Given this list of marker genes Arx, Lhx6, Pafah1b1, Cntn2, Drd1, Sox1 (SRY (sex determining region Y)-box 1), Nkx2-1, Fat3, Rac1, Nr2f1, Fezf1, Reln, Drd2, Ccr4, Evx1, Nr2f2, Fezf2, here is a description of the gene set: Mouse Gene Set: GOBP_INTERNEURON_MIGRATION The orderly movement of an interneuron from one site to another. species: Mus musculus